Given this list of marker genes CISH, IL2, MAPK3, IL2RA, RPS6KB2, SOCS3, GRB2, STAT5B, IL2RB, BCL2, MAP2K1, CRKL, JAK1, RPS6, SHC1 (SHC adaptor protein 1), STAT1, LCK, MAPK1, RAF1, RPS6KB1, FOXO3, MAPT, GAB2, FYN, CCND2, MYC, AKT1, NMI, SYK, PTPN11 (protein tyrosine phosphatase non-receptor type 11), STAT3, SOS1, HRAS, JAK3, IL2RG, PTK2B, STAT5A (signal transducer and activator of transcription 5A), PIK3R1, CBL, FOS, MAP2K2, JUN, here is a description of the gene set: species: Homo sapiens Human Gene Set: WP_IL2_SIGNALING IL2 signaling